The following is a description of a gene set: The aim of this dataset was to study in detail the transcription kinetics initiated by cytokine IL-4 in early differentiation of Th2 cells. Genes up-regulated in comparison of CD4 T cells treated with IL4 and anti-IL12 at 2 h versus the untreated cells at 2 h. from publication Elo LL, Järvenpää H, Tuomela S, Raghav S, Ahlfors H, Laurila K, Gupta B, Lund RJ, Tahvanainen J, Hawkins RD, Oresic M, Lähdesmäki H, Rasool O, Rao KV, Aittokallio T, Lahesmaa R (PMID 20620947) Human Gene Set: GSE17974_IL4_AND_ANTI_IL12_VS_UNTREATED_2H_ACT_CD4_TCELL_UP species: Homo sapiens, and this is the list of marker genes: TAF5LP1, PLEKHH3, DDB2, HEXA, CHD7, TMEM80 (NCBI Gene Id 283232), IL10RA, SATB1, DYNLRB1, TRMT9B, MOB3A, OSGIN2, AMIGO2, PITPNM1, CD200R1, NRAV, MIR21, TRABD2A (TraB domain containing 2A, NCBI Gene Id 129293), DLC1, ZSCAN31, FAM3A, CD47, LINC01304, LUM, CYSLTR1, FMN1, TSLP, SLC37A3, CTSC, MRPL35, TEX36-AS1, UBL3, ME2, C4orf19, IL4R, MTERF2, ST3GAL5, SYNE1, FRMD4B, PCED1B, TCTA, SLC39A8, IFT81, VMP1, SOS1, MOCS2-DT, FAM98C (NCBI Gene Id 147965), CCNB1IP1, TNFRSF10D, AGBL3 (NCBI Gene Id 79914), LINC01192, MAP3K14, NKX2-1-AS1, CFLAR, WNT3, PMF1, PHF20L1, S100A11, BCL2L11, RAVER1, MRPS16, SPPL2C, GNAI1, SLC11A2, SLC3A1, JAML, ENSG00000255537, ZBED2, CD8B, HELLS, LINC03019, DPH5, ATP6V1G3, LINC01289, HHIP-AS1, GATA3, SPIRE2, WDR97, RIPK2, FRAS1, GPCPD1, CD274, MAL, SOCS1, RALB, AACSP1, DENND10, BLTP3B (bridge-like lipid transfer protein family member 3B), RORB, GTF2F2, SLC7A11, APOL6, TRAFD1 (NCBI Gene Id 10906), CPLANE2, SPINT2, EIF2AK2, ZNF443, FARP1, TAS2R8, ETNPPL, MFSD9, FAM241A, CTBP1-DT (NCBI Gene Id 92070), DDT, NSMCE1, ATF5, HNRNPA3P1, CAMK2D, CENPM, EOMES, PTPRE, DACT1, BCL9, ARHGAP32, KRT72, HSBP1L1, PLA2G12B, GPR183, TTC9C, CASP3, PLPP1, STAMBPL1, SNX10, RWDD3, H2BC21, SLC40A1, PAFAH1B3, TESPA1, FAM13A, MAP3K1, ENSG00000213963, OR6W1P, RASGRP1, LINC02874, TREML2, CHST10, HECW2, SLC6A18, NDFIP2, ERVFRD-1, TEX30, CARF, SGSH, OR51J1, HABP4, SAYSD1, ANKIB1, CLEC4A, SUV39H1, TADA3, ARHGAP25, MTUS1, MMP16, PABPC1L2B, ZNF462, S1PR1, IFT57, RASGRP3, EXD3 (exonuclease 3'-5' domain containing 3), KLRG1, DZIP3, RAB11FIP1, DHRS9, RDH5, ZNF436-AS1, PTGER2, TMEM273, KRT222, XBP1, GPRIN3, LRRN3, SOX9-AS1, RAB30, STK17B, ADAD1, UGT2B4, MRPL23, ZNF784, TMEM200A, NCOA3, LEISA1, RAB11A, RNF125, MRPL38, AXIN2, MAPKAPK3, MBLAC1, LINS1, CISH, CFAP107, THAP7, PECAM1, CLUHP3, PTGIR, NKX6-2, KCTD12, SAE1